The following is a description of a gene set: species: Homo sapiens Developmental defect characterized by an anomalous anatomic location of the heart. Human Gene Set: HP_ABNORMAL_ANATOMIC_LOCATION_OF_THE_HEART Abnormal anatomic location of the heart, and this is the list of marker genes: IFT74, ARMC9 (armadillo repeat containing 9), DNAL4, CFAP298, GLI1, CFAP45, ODAD2, NEK10, ACVR2B, DAW1, CSPP1, WT1, RSPH3, RPGRIP1L, TMEM218, MSX1, CCDC39, GAS2L2, ANKS6, PRRX1, PQBP1, TCTN3, GATA4, DNAJB13, RPGR, CLXN, CFC1, HES7, CCDC103, MCIDAS, IFT56, ZIC3, DNAH1, CCDC40, PIBF1, OFD1, RSPH4A, MEGF8, STK36, LMNA, NME8, DNAAF2, DNAI1, SH2B1, PRKACB, CRELD1 (cysteine rich with EGF like domains 1), DNAH5, CEP120, TMEM237, MYRF, EVC2, ODAD4, MKS1, CFAP52, COL18A1, CCNO, B9D1, NPHP3, CPLANE1, ZMYND10, ARL3, CC2D2A, DYNC2LI1, DNAAF1, MNS1, TGDS, NODAL, DNAH9, TCTN1, ZMPSTE24, PKD1L1, CFAP53, SPEF2, B9D2, TMEM216, ZFX, PACS2, FANCB, DNAAF4, LRRC56, TXNDC15, LMBRD1, SUFU, KATNIP, NECTIN1, CEP290, GDF1, DNAAF6, TOGARAM1, BRWD1, TMEM107, SMAD2, DNAI2 (NCBI Gene Id 64446), FOXJ1, CEP104, SPAG1, DRC1, CFAP74, CIROP (ciliated left-right organizer metallopeptidase), HYLS1, CBY1, PDE6D, ROBO1, NME5, INVS, TTC8, DNAAF5, DNAAF3, CFAP221, PIEZO2, CDH2, PRKACA, INPP5E, ZNF423, OTX2, BCOR, SRCAP, SLC19A2, HYDIN, NEK8, TP63, CFAP300, DNAH11, MMP21, RTTN, TCTN2, TMEM231, TTC12, ARL2BP, RSPH9, RPGRIP1, PAK2, IRF6, AHI1, ARL13B, TMEM67, ODAD1, UBR1, PKD2, LZTFL1, KIAA0586, CEP41, SLC38A3 (NCBI Gene Id 10991), DNAAF11, EVC, CCDC65, RSPH1, DNAL1, ODAD3, KIAA0753